Given this list of marker genes Dbr1, Lrsam1, Rps28 (ribosomal protein S28), Ndufa11 (NADH:ubiquinone oxidoreductase subunit A11), Myocd, Cox7b, 4930539J05Rik, Asph, Wdr77, Thap7, Atg13, Zfand2b, Pcp4l1, Rps6, Anapc16, Fuz, Cdc20, Zfp566 (zinc finger protein 566), Gm15728, Tmem134, Chst12, Dpp8, Copb2, Phf12, Mrpl40, Micos10, Mrps7, Stk38l, Lsm8, Nop14, Riox1, Snhg9, B230219D22Rik, Sec23ip, Smg5, Styxl1, Psmd1, Timm13, Agbl3, Slc25a4, Mgme1, Slc5a6, Naa35, Cenpu, Arid1a, Trp53, Six1, Etf1, Gdf9, Npm1, 2810402E24Rik, Lnx1, B230354K17Rik, Etl4, Lyrm7, Siah1b, Ift46, Gm9929, 2900052L18Rik, Gpatch3, Esam, Exo5, Cox11, Mafg, Zmym3 (NCBI Gene Id 56364), Yy1, Troap, Ubr3, Josd2, Cdc14a, Dhx9, Rps15, Myl12a, Cacna1c, Hhatl, Slc19a2, Ppp2r5b (NCBI Gene Id 225849), Rbm39, Srd5a3, Bzw1, Prdx1, Sugp1, Polr1c, Ckm, Lrrc10, Snord1c, Ncor2, Coro1c, 6030469F06Rik, Rab10os, Harbi1, Ehd1, Prkag2, Stard3, Zcchc14, Odr4, 3110083C13Rik, Rc3h2, Btbd10, Usp53 (NCBI Gene Id 99526), Alg12, Or2at4 (NCBI Gene Id 259066), Aph1b, Haspin, Psmb2, Ufd1, Eif4g2, Nhlrc3, Pik3r2, Zbtb7c, Eif4a3, Ikzf5, Ptges3, Ints13, Tent4b, Asxl1, Kctd5, Mrps14, Mysm1, Ppp2r3c, Tbcd, Cacnb2, Mia2, Polr1f, Uhrf2, Selenbp1, Erp29, Hspa4, Endov, Timm17a (translocase of inner mitochondrial membrane 17a), Gm6410, Exosc10, Suv39h1, Pde4d, Nfib, Rnf4, 1600012H06Rik, Katnip, Ankrd13c, Scaf8, Mbtps1, Yipf3, Mau2, Uck2, Akap9, Fam76a (family with sequence similarity 76, member A), Zfp62, Tmem79, Gm1335, Stag3, Tubgcp5, Nbr1, Mideas, Vgll4, Cebpa, Dnajc27, Eif2s2, Igfbp4, N4bp2l2, Zzz3, Ramac, Dnajb4, 6030445D17Rik, Gm23301, Smdt1, mt-Th, Proser1 (NCBI Gene Id 72683), B430010I23Rik, Nudt18, Hells, Stox2, Cand1, Rab33b, Gm15564, Etfa, Abhd18 (abhydrolase domain containing 18), Smndc1, 6430590A07Rik, Spata33, mt-Tl2 (NCBI Gene Id 17736), Cdc26, Supt5, Bmf, Tas1r1, Xpc, Fbxl19, Atf2, Ndufa7, Rps7, Puf60, Ergic2, Ten1, Nup58, Ift74, Retreg1, Pomt1, Rpl27, Depdc1b, Srsf10, Hspb7, Ptrh2, Mad1l1, Trappc2, Gm13610, Pam, Ppp4r3b, Adprhl1, Gnb2, Clptm1, Cd2ap, Cavin2, Ltbp4, Sf3a2, Dcaf6, Banp, Gm36447, Mov10l1, Usp47, Chd2, Smim13, Ssmem1, Smc4, Snrpd3, Snora64, Nprl3, Ap4e1, Twf2, Thap1, Gm12694, Wdr6, Kin, Ofd1, Tdp2, Gga3, Trim72, Amz2, Atp5f1c, Hdac5, Ppip5k2, Rpp38, Hnrnpl, Acsm5, Lsm3, Rps2, Tcf25, Snapin, Marchf7, Rab6a, Ciapin1, Cyc1, Ttc14, Coq9, Lrif1, Gm11732, Cntn2, Acot13, Eif5 (NCBI Gene Id 72643), Izumo1, Sardh, Atg4c, Ncl (NCBI Gene Id 319677), Rnu12, Calm2, Acadsb, Phf5a, Tpt1, Robo2, Clic5, Rxrb, Gpc2, Alpk2, Zfp346, Ninl, Fam13b, Ablim1, Pygo2, 2010310C07Rik, Qrich1 (NCBI Gene Id 69232), Tmem107, Cyb5r4, Cltc, Lrtm1, Mdh2, Haus4, Pbld2, Slc35b1, Ska3, 5430416N02Rik, Ctsh, Mfge8, Lsm14a, Zbtb40, Utp11, Fitm2, Nfyc, Tab2, Rpl27a, Shld1, Ddx20, Lrrc28, Vps4b, 4930447C04Rik, Gm14963, Atn1, Chuk, Rbm15, Pop7, Cdk8, Stxbp4, Dnajc14, Cenpt, Gm29346, Rabl6, Sec62, Brca1, Sorbs2, Nudt1, Sugp2 (SURP and G patch domain containing 2), Rnpc3 (NCBI Gene Id 99626), Gm7467 (predicted gene 7467), Mef2a, Hsbp1, Ino80, Cdca3, Gm20186, Polr2e, Lnpep, Fadd, Kdf1, Prcc, Zfp386, Pxk, Ttc32, Smarcd1, Myh7b, Poldip3, Strip1, 4833439L19Rik, Ccdc62, Nanp, Trim37, Pou4f1, Sec63, Hnrnph3, Rad51ap1, Bod1, Sertad2, Arf3, Borcs5, Snora3, Snx5, Mical2, Kpna2, Map2k2, Phactr1, Gm4468, Zfp367, Sertad4, Prorp, Ambra1, Zc3h4, Tardbp, Zfp397, Dctn2, Grk4, Herc3, Rps3a1, Glce, Ppcdc, Mir6236, Ddhd2, Dffa (DNA fragmentation factor, alpha subunit), Ncoa4, Hexim2, Rfesd, Tmem183a, Ift80, Nkrf, Dnai1, Doc2g, Zhx1, Gm26704, Idh1, Rptor, Mapk14, Dars1, Mrpl44, Baz2b, Fat1, Srcap, Rpl12, Rgcc, Macrod2, Upf3a, Rpl10a, Art5, Neu3 (NCBI Gene Id 50877), Dmxl1, Rab5c, Zfp106, Acox1 (acyl-Coenzyme A oxidase 1, palmitoyl), Pigyl, Matr3, Kmt2d, Elf1, Gm16124, Srsf5, Tmem267 (transmembrane protein 267), Wrap53, Ggnbp2, Cry1, Atp5pb (NCBI Gene Id 97048), Hps5, Atp5mc2, Dzip3, Gm11511, Herpud1 (homocysteine-inducible, endoplasmic reticulum stress-inducible, ubiquitin-like domain member 1), Smarca5, Wdfy1, Mtus1, 1600023N17Rik, Rbm26, Atxn2l, Epo, Abr, Chaf1a, Nsd3, Cyb5d1, Rps15a, Ankfy1, Dido1, Cdc45, Sp2, Nktr, Sf3a3, Rraga, Ep300, Gm15270, Ppp1r2, Klhdc4, Pkd2l2, Mre11a, Cenpb, Luc7l2, Gnpda1, mt-Nd5, Gm23969, Gmppa, Ksr2, Spc25, Psmd5, Akap1, C2cd5, Naa25, Filip1, Nol9, Dnah17, Aen, Khsrp, Prpf4, Stip1, Rfc5, Rps19 (NCBI Gene Id 20085), 3110070M22Rik, Akap11, Tpr, Dguok, Mob1a, Inf2, Idh3g, Ube2d3, Nmd3, Rmi1, Erc1, Pdk1, Gm5547, Gngt2, 1700096K18Rik, Cwc22, Tmem209, Snrpg, Plxnd1, Myef2, Fgfr1op2, Csde1, Hnrnpk, Trabd2b, Chmp1a, Gtf2h1, Gm15473, Dnttip2, D230022J07Rik, Srsf4, Gm22394, Ist1, Ubl3, Cip2a (cell proliferation regulating inhibitor of protein phosphatase 2A), Camk2d, Ptgs1, Mfsd8, Kcnk3, Lgr6, Slain2, 1110025M09Rik, Gpr155, Atraid, Lin7c, Mylk3, Dis3 (NCBI Gene Id 72662), Myorg, Spdl1, Nsun3, 9130604C24Rik, Agtpbp1, Sipa1l1, Lsm11, Mrpl17, Ptgr2, Mbd2, Ube2d2a, Slc9a1, Ctdsp1, Snhg8, Ppp1r12a, Frmd5, Naa38, Fam219a, Nptn, Tspyl1, Esyt2, Uqcrq, Cdc5l, Tsc22d1, Card10, Plekhj1, Mrpl57, Nt5dc3, Crebzf, Hibch, Usp5 (ubiquitin specific peptidase 5 (isopeptidase T)), Grb2, Slc25a28, Skint7, Aldh4a1, Mfsd13a, Ireb2, Apoh, Polr2b (polymerase (RNA) II (DNA directed) polypeptide B), Styxl2, Pcmtd1, Ptpn4 (NCBI Gene Id 56545), Fsip1, Vmac, Atpsckmt, Clip2, Rxra, Cct5, Slc39a7, Pdss1, Agl, Nop58, Bod1l, Bckdk, Gm20619, Gm11476, Gin1, Raly, Stk40, mt-Tp, 4930579K19Rik, Med6, Ncapg, Fam135a, Tonsl, Pdk2, Cul5, Cops3, Tmem116, Mcts2, Ccnt1, Arl2bp, 1700052H01Rik, Cfap53, Nucb1, Zkscan2, Drg1, Edrf1, Snhg16, Mef2d, Fanca, Micu2, Rpl7a, Lamp1, Carmil1, Map3k7, Aco2, Tead1, Mpc2 (mitochondrial pyruvate carrier 2), Pcnt, Ercc6l2, Smim5, Mir5133, Snora78, Fzd6, Apobec2, Kpnb1, Herc1, Thada, Cct8, Kif24, Icmt, Gucd1, Ate1, Ddc, Eif2ak4, Pam16 (NCBI Gene Id 66449), Rpl8, Ssbp1, Frmd8os, Slc39a9, Hdhd3, Nol11, Fitm1, Cish, mt-Ts2, Ankrd1, Zfp512b, Hira, Lsg1, Gorasp2, Cdk12, Supt16, Smim19, Fubp1, Ahctf1, Gemin7, mt-Cytb, Gm26590, Ssr4, Fancc, Nosip, Srp19, Med22, Mir5122, Zfp219, Vmp1, B130034C11Rik (RIKEN cDNA B130034C11 gene), Snord58b, Fos, Snora24, Wdr73, Gm17484, Ap1m1, Kazald1, Golm2, Sf1, Thap11, Stap2, Mettl16, Mms22l, Pten, Tab3, Atf6, BC004004, Aip, Slc4a3, Gpsm1, D6Wsu163e, Tasor2, Slc35b4, Tipin, Creld2, Srebf1, Cd2bp2, Rpl17, Stx4a, Ces3b, Gid8, Lypla1, a, Sh3kbp1, Srrt, Zfp691, Cep104, Dffb, Gm4285, Get4, Erh, Adcy6, Traip, Tigd2, Scamp5, Nudt2, Gm27011, Rpl26, Noa1, Tmco1, C130036L24Rik, Denr (density-regulated protein), here is a description of the gene set: Genes containing one or more binding sites for (Tbx20) in their promoter regions (TSS -1000,+100 bp) as identified by GTRD version 20.06 ChIP-seq harmonization. from publication Yevshin I, Sharipov R, Kolmykov S, Kondrakhin Y, Kolpakov F (PMID 30445619) species: Mus musculus Mouse Gene Set: TBX20_TARGET_GENES